The following is a description of a gene set: Presence of multiple small cysts containing keratin (skin protein) and presenting as tiny pearly-white bumps just under the surface of the skin. Human Gene Set: HP_MILIA studied in species Homo sapiens Milia, and this is the list of marker genes: LAMB3, PPOX, PLEC, PTCH1, SMARCAD1, ITGB4, LAMC2 (NCBI Gene Id 3918), FERMT1, COL7A1, CYLD, COL17A1, OFD1, KRT5, LIFR, KRT14 (NCBI Gene Id 387571), MMP1, LAMA3